Given this list of marker genes CREBZF, MED13, ATP6V0E2, DGKA, BCL11B, WDR33, PITPNM1, MYADML2, PRKACB, RSF1, YPEL3, TMEM63A, PARD3B, SMAD7, INPP5K, RNF25 (ring finger protein 25), PTBP2, FAM78A, CORO1A, TMEM168, ARHGEF18, TRAF1, PTPN22, EXT1, PECAM1, CAST, NEDD4L, ATAD2B, ABLIM1, LRRC43, FMN1, CDK20, RAB11FIP1, SORL1, RBM28, SLC26A7 (NCBI Gene Id 65015), DDX46, XPR1, SLC25A41, ZNF394, POLD4, TECPR1, PPP6R3, CILK1 (ciliogenesis associated kinase 1), INPP4B, GARIN1A, TXNIP, SELL, DHRS7C, CHD1, PLCL2, SSH2, AGPS, TAOK1, RAD51D, IPCEF1, GIMAP3P, HLCS, PLA2G3, TMEM30B, CFAP144P1, CRIM1, ELL, CAVIN4, SLC27A2, TOM1, STAT4, ADD3, ELMOD3, FNDC8, CHD7, PPP6R2, GRAP2, ITSN2, RIPOR2, MYBPC3, CYTIP, PREX1, MAGEE1, ZEB1 (NCBI Gene Id 6935), ADSS2 (NCBI Gene Id 159), TRIM40, LARS2, ATP1B3, LONRF3, TMEM59, RCSD1, FRS2, TBC1D23, DDX5, RFX3 (NCBI Gene Id 5991), KCTD11, LRRC61, IREB2, S1PR1, LASP1, SNAPC3, MAP3K7 (NCBI Gene Id 6885), SMC4, BRMS1, FBXO22, LCK, PPM1H, UNKL, MIER1, ZNRF1, TNKS, TAX1BP1, SLC17A8, FHIP1B, PLCXD2, STT3B, RANBP9, FGGY, MLLT10, PHIP, ACBD3, FAM133B, CSNK1G2, IL2RB, NR3C1, CUL3, ZC3HAV1, LEF1, HACE1, DDX6, ILK, TOP2B, MAPK14 (mitogen-activated protein kinase 14), LYPD6B, PAIP1, ELOVL5, ZFAND3, PELI1, SENP7, ARMC2, GJC2, MYH9, PTPRC, RDH12, SENP2, ARHGAP9, OLFML3, PIM1, BRF1, TCF7, YTHDF1, SIPA1L1, ABI1, FCHO2, GNAI2, ARHGAP4, TAF5L, ERBIN, TSEN15, VTI1A, GIMAP6, STK38, CD9, ABCB9, HECTD1, PRKCQ, SYNGR4 (synaptogyrin 4), JAK1, TSPAN13, IFT80, SEPTIN6, LRRIQ1, ITCH, PAN3, DGKE, SPICE1, CCDC126 (coiled-coil domain containing 126), CASP8, here is a description of the gene set: species: Homo sapiens from publication Zhang W, Ferguson J, Ng SM, Hui K, Goh G, Lin A, Esplugues E, Flavell RA, Abraham C, Zhao H, Cho JH (PMID 22715389) Human Gene Set: GSE32901_TH1_VS_TH17_ENRICHED_CD4_TCELL_UP Genes up-regulated in CD4 T cells: Th1 versus Th17 enriched. In this study, we examined differential gene expression in naïve human CD4+ T cells, as well as in effector Th1, Th17-negative and Th17-enriched CD4- T cell subsets. We observed a marked enrichment for increased gene expression in effector CD4+ T cells compared to naive CD4+ among immune-mediated disease oci genes. Within effector T cells, expression of disease-associated genes was increased in Th17-enriched compared to Th17-negative cells. We used microarray to examine the gene expresssion profile and level of human naïve, Th1 and effector T cell subsets.